Given this list of marker genes Csnk2a1, Atg12, Map1lc3a, Fundc1, Atg5, Csnk2b, Csnk2a2, Ulk1, Src, Pgam5, Map1lc3b (NCBI Gene Id 67443), here is a description of the gene set: studied in species Mus musculus Mouse Gene Set: REACTOME_RECEPTOR_MEDIATED_MITOPHAGY Receptor Mediated Mitophagy